The following is a description of a gene set: species: Homo sapiens IL-27 treated DCs were shown to be highly potent inhibitors of cis HIV-1, particularly of CCR5 tropic strains. Microarray studies of IL-27 treated DCs showed no up-regulation of Type I (IFN) gene expression. Neutralization of the Type-I IFN receptor had no impact on the HIV inhibition. Lastly, IL-27 mediated inhibition was shown to act post-viral entry and prior to completion of reverse transcription. These results show for the first time that IL-27 is a potent inhibitor of cis HIV-1 infection in DCs by a Type I IFN independent mechanism. Human Gene Set: GSE44732_UNSTIM_VS_IL27_STIM_IMATURE_DC_UP from publication Chen Q, Swaminathan S, Yang D, Dai L, Sui H, Yang J, Hornung RL, Wang Y, Huang da W, Hu X, Lempicki RA, Imamichi T (PMID 23527130) Genes up-regulated in immature dendritic cells: untreated versus IL27., and this is the list of marker genes: ZNF532, APOO, MYCL, ECHS1, EHHADH, MAP3K13, PRPS1, CSF2RB, CCL17, SCARF1, TEX36 (NCBI Gene Id 387718), MRPS5, NPIPA1, PLD4, POP1, CD1A, PHLDA2, DUSP5, LMNB1, DDA1, ZER1, CAMKK2, ARHGAP31, AP1G2, DOCK1, KIAA1671, ISYNA1, LRP8, H2BC10, DUSP22, SYNGR3, ZNF641, MRTFA, ZC3HC1, APBA3, PLPPR2, GPD1L, FHL2, STARD10, CTTN, FA2H, CYREN, RRP36, ZCWPW2, PON2, ARPC5L, NME4, FKBP5, GPBP1L1, VPS35L, RBM10, CYTIP, CAMK1G (NCBI Gene Id 89759), ASAP1, FAM168B, TNFAIP8, CSF2RA, RFTN1, NCOR2, RBMS2, TERF2, PTMS, ABL2, NDUFV2, TSPAN33, FSCN1 (NCBI Gene Id 6624), KATNAL1, CREBL2, H3C6, ZFP3, HEXIM1, GNG7, TNFRSF4, TPM3, SLC2A4RG, CLSTN1, C14orf28, CLEC7A, UQCRFS1, SH3BP4, RAP1GAP, TTC9C, PPA1, LTV1, IMP4, SLC9A5, GABPB1, CDKN1A, INTS3, MEGF8, C15orf39, OLA1, AGPAT1, RPS27L, GTPBP8, USP53, TRIB3, FLOT2, GANC, SLC2A4, SLC16A9, RABGAP1L, CD1B, TUBA4A, CD1E (CD1e molecule), RYR1, MTCL1, STARD7, ZMIZ2, EIF3D, CHRAC1, FAIM2, CFLAR, ATP5F1B, PTGER4, BDH1, HSPBAP1, TAPT1, ACOT11, SUB1, TRIP10, MAN2A2 (mannosidase alpha class 2A member 2), RAB8A, RPRD1A, CYP2S1, BBOF1, IL1RAP, RIOX2, CMPK2, GPX2, RNF126, ZNF598, MVB12B, MAD2L2, HOMER2, IMPDH2, FHOD1, DNMT1 (DNA methyltransferase 1, NCBI Gene Id 1786), GDI1, SEMA7A, HLA-DMB, H2BC9, FXYD2, VDAC2 (voltage dependent anion channel 2), GPAT3, R3HDM1, INS, FGL2, TDRD7, CASP2, IRF5, PRRC2A, PSTPIP2, UQCR10, NOPCHAP1, FMNL3, TNF, FZD1, ERICH1, PMM1, PALD1, MAN1C1, NLRC5, HELZ2, CDR2L, EYA3, GNE (glucosamine (UDP-N-acetyl)-2-epimerase/N-acetylmannosamine kinase), HLX, NUB1, LGALS1, DIAPH1, RUNX3, COMTD1, DNAJC11, HCFC1, TREML2 (NCBI Gene Id 79865), GPR68, IL2RG, CNPPD1, NDUFA12, ZBTB46, GGT5, FNBP1, CACYBP, MPZL3, U2AF1L4, RAB7A, WDFY4, NAGPA, RPTN (NCBI Gene Id 126638), SHCBP1, EOLA1, SUFU, RASSF4, CDH2, GDI2, BLOC1S6, ENTREP1, TRIM28